The following is a description of a gene set: species: Mus musculus Genes down-regulated in 10T1/2 cells (multipotent mesoderma) by expression of SHH. from publication Ingram WJ, McCue KI, Tran TH, Hallahan AR, Wainwright BJ (PMID 17873912) Aberrant regulation of signalling mechanisms that normally orchestrate embryonic development, such as the Hedgehog, Wnt and Notch pathways, is a common feature of tumorigenesis. In order to better understand the neoplastic events mediated by Hedgehog signalling, we identified over genes regulated by Sonic Hedgehog in multipotent mesodermal cells. Widespread crosstalk with other developmental signalling pathways is evident, suggesting a complex network of interactions that challenges the often over-simplistic representation of these pathways as simple linear entities. Hes1, a principal effector of the Notch pathway, was found to be a target of Sonic Hedgehog in both C3H/10T1/2 mesodermal and MNS70 neural cells. Desert Hedgehog also elicited a strong Hes1 response. While Smoothened function was found necessary for upregulation of Hes1 in response to Sonic Hedgehog, the mechanism does not require gamma-secretase-mediated cleavage of Notch receptors, and appears to involve transcription factors other than RBP-Jkappa. Thus, we have defined a novel mechanism for Hes1 regulation in stem-like cells that is independent of canonical Notch signalling. Mouse Gene Set: INGRAM_SHH_TARGETS_DN, and this is the list of marker genes: Sparc, Dram1, Gas6, Sertad1, Ajuba, Emc2, Tppp3, Pgm5, C3, Slpi (secretory leukocyte peptidase inhibitor), Ccl9, H2-T24, 4933401B06Rik, 0610030E20Rik, Sfrp2, Ereg, Cdc37, Nrep, Maged2, Aoc3, Lrrc17, Mrpl54, Septin12 (NCBI Gene Id 75648), Mme, Emb, Ptn, Gna12, Ptx3, Pou3f1, Tyk2, Hgf, Clu, Tgfbi, Ret, Slc1a3, Eeig2, Ppm1d, Diras2, Brpf1, Endod1, Crlf1, Wnt5b, Kdm8, Evl, Angptl4, Col1a1, ENSMUSG00000126933, Il1rn, Megf10, Ccne1, Glrx, Daxx, Itgb7, Ache, Or13c7e-ps1, Prdx4, Snd1, Tuba1a, Calcrl, Ecrg4, Vcan, Cav2, Bambi, Plk4, Sfrp1, Sdc1, Gpm6b